Given this list of marker genes SNRNP200 (NCBI Gene Id 692221), GTF3A, TARDBP, RPL5 (NCBI Gene Id 90045), MTIF2, RPS17, APEX1, RPS23, CNOT7, RPL27, HINT1, RPL29, PMPCB, RPS8, EIF4B, NAP1L1, EIF3E, HDAC1, NACA, PABPN1, HMGN1, HNRNPC, LSM8, TCERG1, RPS15, DAP3, HSPA14, DIMT1, RBM15, SRSF2, SNRPD2, DDX39B, SYNCRIP, KHDRBS1, RPS16, AIMP1, RPL19, RBMX, RBM12, RPL6, EPRS1, SRSF1, RPL14, RBBP6, NAE1, RPS21, TAF1D, RACK1, IFT25, TRA2B, RPSA, UBE2I, HNRNPA1, EIF3H, NOC3L, SNRPD3, PTMA, RPL3, RPL13A, PWP1, RPL35, RPS10, MRPL9, EIF2S3, SRSF3, KPNB1, RPS29, EEF1B2, U2SURP, PUM3, RPS12, HNRNPA2B1, RBM10, SNRPE, DHX15, RPS7, NONO, CPSF6, EIF3L, NCL, PPIA, RPL9, DKC1, LSM7, UXT, COX7C, BTF3, ST13, KARS1, HNRNPD, NOL7, RPS4X (ribosomal protein S4 X-linked), FBL, RPL35A, RPL28, RPS2, RPS3, NSA2, CCDC59, RPL15, RPL12, RPL24, RPL23A, RTRAF, EIF3D, SRSF7, RPS6, SRRM1, SF1, PPIH, EEF1G, POLR1D, RFX5, DDX50, NUP210, RPL37, RPL7, UTP3, RPL13, RPL7A, NOL11, RPL38, RPL32, RRP1B, POLR3E, RPL8, ATP5MC2, MRPL16, XPO1, RPL36, HNRNPF, RPS19, RPL17, RPS20, RPL10A, SRSF10, NPM1, KANSL2 (KAT8 regulatory NSL complex subunit 2), SUZ12, EXOSC8, RPL4, RPL22, RPS25, NSUN5, SLC7A5P1, HNRNPR, here is a description of the gene set: Neighborhood of FBL Human Gene Set: GNF2_FBL studied in species Homo sapiens Neighborhood of FBL fibrillarin in the GNF2 expression compendium